Given this list of marker genes Tgfbr2, Bmp7, Tgfb2, Exoc4, Nog, Tbx2, Smad3, Robo1, Eng, Heyl, Tgfbr1, Smad4, Acvrl1, Nckap1, Mdm2, Ctnnb1, Adamts5, Myc, Lef1, Acvr1, Bmpr1a, Bmp4, Acta1, Snai1, Nos3, Taf10, Bmp2, Aplnr, Rbpj, Snai2, Msx1, Tmem100, Foxf1, Tbx3, Acta2, Htt, Tgfb3, Fgf8, Tgfb1, Wnt11, Dchs1, Osr1, Wnt3a, Hnf1a, Isl1, Hey1, Foxc2, Notch1, Actc1, Mdm4, Robo2, Wnt5a (wingless-type MMTV integration site family, member 5A), Bmp5, Tbx20, Gata5, Fgfr1, Twist1, Sox9, Smad2 (SMAD family member 2), Cplane2, Foxc1, Actg2, Msx2, here is a description of the gene set: Mouse Gene Set: GOBP_MESENCHYME_MORPHOGENESIS The process in which the anatomical structures of a mesenchymal tissue are generated and organized. A mesenchymal tissue is made up of loosely packed stellate cells. species: Mus musculus